The following is a description of a gene set: Human Gene Set: GOCC_EXTERNAL_SIDE_OF_PLASMA_MEMBRANE species: Homo sapiens The leaflet of the plasma membrane that faces away from the cytoplasm and any proteins embedded or anchored in it or attached to its surface., and this is the list of marker genes: BTNL3, BTN3A2, ERMAP, CD1A, CSF2RA, TAS2R16, HYAL2, LY6G5C, KLRC1, BTNL2, IL23R, IZUMO1R, KIT, CD14, ULBP2, VTCN1, SLC4A3, ADAM20, SELP, LILRB1, CXCL9, CD226, RAET1E (NCBI Gene Id 135250), CTLA4, ITGB1, MOG, ENOX1, ROBO4, CCR4, CUBN, IDE, FGF8, THY1, AZGP1, BCAM, MILR1, PKHD1, LY6G5B, GPIHBP1, IL31RA, ITGA6, BTN1A1, IL7R, CD1E, GP1BA, SLC2A4, CD34, CCRL2, FCGR1A, CXCR2, FCGRT, P4HB, HLA-E, TCN2, COLEC11, IL4R, CD74, P2RX7, CXCR5, ITGAM, GSR, SLAMF9, CD207, FCGR3B, PCSK9, ACKR3, ST14 (NCBI Gene Id 6768), CCR7, KLRC3, SCNN1B, CRLF1 (NCBI Gene Id 9244), TNFRSF4, CD276, CD86, CCR9, ULBP3, FGA, TRGV1 (NCBI Gene Id 6973), ITGB3, GP2, PLAU, IL13, HLA-A, MAP3K5, MCAM, FAS, TFRC, CSF3R, CSF2RB, FCRLB, FCGR2B, ANTXR2, ANTXR1, IL13RA1, SCNN1A (sodium channel epithelial 1 subunit alpha), LY6G6D, PTPRC, CCR10, TRPM8 (NCBI Gene Id 79054), ADGRE1, SDC1, CA4, CD69, HLA-G, CLEC4C, C17orf99, FCRL3, BTNL10P, CXCR3, TGFBR2, LRP2, CHRNB2, LEPR, GFRAL, ACKR4, CLEC4E, ITGA7, APP, IL17A, GRIA2, FLOT1, CLEC17A, MUC17, CTSK, CLEC4D, SLAMF6, MBL2, FASLG, HLA-C, FCRL6, ULBP1, TRGC1, PDCD1LG2, CLEC4G, CALR, CD163L1, AMOT, CLEC14A, CD5, LRRC24, DAG1, CCR2, B4GALT1, IL2RA, FCGR2A, HEG1, BTN2A2, CNTFR, PDCD1, MPL, TRGV2, GRIA1, SERPINA5, CD40LG (CD40 ligand), FCGR3A, CD79A, MS4A1 (NCBI Gene Id 931), HLA-B, ITGA4, ITGA11, F2, TNFRSF14, FCN2, RAET1L, CLEC2A (NCBI Gene Id 387836), ITGA9, FCRL1, PLET1, CX3CR1, ITGA3, B2M, S1PR1, CD84, ASTN1 (NCBI Gene Id 460), FOLR2, IGSF21, KCNJ3, PRLR, PECAM1, FCER1A, BTNL9, ENTPD1, ITGB2, CTSB, IL5RA, LCT, CD19, COLEC10, FGB, FOLR3, KLRK1, CD2 (NCBI Gene Id 914), RTN4R, ICOSLG, MR1, GHR, UMODL1, HLA-DRB1 (NCBI Gene Id 730415), CHRNA4, SCUBE1, IL12RB1, FCRL5, CD83, ATP1B2, KLRC4, CRLF2, CXCR1, XCR1, THBD, CCR5, SPN, IL1R1, CD22, TFR2, FCGR1BP, CD1D, PLG, LDLR, ITGA8, CLEC2D, CD33, EPHA5, BTN3A1, LY9, TLR4, F10, HLA-H, ABCG1, BTN3A3, CCR6, TNFRSF11A, ADAM29, VCAM1, FCRLA (NCBI Gene Id 84824), DNAI2, LAG3 (NCBI Gene Id 3902), KLRC2, ANPEP (NCBI Gene Id 290), BTN2A1, ATP6AP2, IL6R, TRGV10, FCER1G (Fc epsilon receptor Ig), CD40, HFE, KDR, HHLA2, TNF, TRGV3, CDH13, ACKR2, ACE, MFGE8, RS1, ITGA5, CD59 (CD59 molecule (CD59 blood group)), ABCB1, ANXA5, ADGRA3, ITGA2B, IL13RA2, FOLR1, CD24, ADAM30, LY75, CEACAM21, CDH5, IL12RB2, THBS1, TNFRSF13C, SLC7A5, KLRD1, SLAMF7, ECE1, CAPN2, GFRA4, ICAM1, TMC1, EFNA5, SPA17 (NCBI Gene Id 90953), ITGA1, FCN1, ITGAL (integrin subunit alpha L), RTN4RL2, ADAM9, CXCL10, CXCR4, MUC16, GFRA1 (GDNF family receptor alpha 1), BTNL8, SELL, CLCN3, CD244 (CD244 molecule), SCNN1G, CD209, CLEC6A, GFRA3, CLEC4A (C-type lectin domain family 4 member A), ABCG2, TMEM123, SLAMF1, STAB2, KLRC4-KLRK1, GFRA2, CLPTM1, MS4A2, PLAUR, SLC22A11, LAMP1, SELE, CD28, GPC4, TRGV8, CD248, CD163, CD3G, INSR, NRCAM, ITGAE (NCBI Gene Id 3682), ALCAM, GLRA1, FCN3, RTBDN, CD1C, CD80, CCR1, FCER2, FCRL2, CD36, TRGV5, TNFRSF18, CLEC12B, ADAM21, CD4, CD27, RAET1G, CLEC10A, PRND, SEMA7A, ENPEP, EPOR, ITGAD, BMPR1A, ASGR2, CLEC4M, CLEC4F, MICA, ABCA1, CXCL12, IL6ST, IL2RG, TNFRSF9 (NCBI Gene Id 3604), LIFR, ASGR1, CD1B, AQP4, CXCR6, PDGFRA, LY6G6C, IL2RB, IL1RL1, CCR8, HLA-F, CD79B, IL21R, CD274, CD8A, CD9, OSMR, ABCC4, ITGA2, CD200R1L, TLR8, FCRL4, SLC38A1, FGG, NT5E, MICB, TGFBR3, TRGV9, P2RX1, CD200R1, TRGC2, ENOX2, IL3RA, F3 (coagulation factor III), ITGA10, ENG (NCBI Gene Id 2022), CCR3, IL9R, IL11RA, TRGV4, ITGAV, ENPP3, CD3E, ITGB6, PRNP, ADA, BTN2A3P, ITGAX, FCGR2C, NCAM1, CD3D